The following is a description of a gene set: Changes in mouse liver mRNA profiles following intraperitoneal cytokine injection. Either interferon-gamma-/-, albumin-cre(-) Socs3(w/fl) mice, or albumin-cre(+) Socs3(-/fl) mice were injected with either phosphate-buffered saline, interferon-gamma, or interfeukin-6, and livers taken after 4h. from publication Croker BA, Krebs DL, Zhang JG, Wormald S, Willson TA, Stanley EG, Robb L, Greenhalgh CJ, Förster I, Clausen BE, Nicola NA, Metcalf D, Hilton DJ, Roberts AW, Alexander WS (PMID 12754505) studied in species Homo sapiens Human Gene Set: GSE369_SOCS3_KO_VS_WT_LIVER_UP Genes up-regulated in livers: SOCS3 knockout versus wildtype., and this is the list of marker genes: GOT1, SHQ1, SLC7A1, METAP2, WDR18, NUP85, BID, ELOVL6, RAP1GAP2, GOLM2, IRAG1, SPART, C1orf198, RAB33A, NPL, TRIP13, AATF, WDR55, MRPS5, XPOT, FDPS, HSPB2, RBM34, MTHFD2, DDX31, MALSU1, C21orf91, RPAP2, FOXRED1, TMEM248, PRELID2, SNRPA1, SLC7A6, PBDC1, AKAP1, HMBS, EIF6, DRC1, NUTF2, CS, TMED1, COMTD1, NOP2, SKIC3, FBXO31, TFB2M, ORC3, HSP90AA1 (NCBI Gene Id 89272), ITGB1 (integrin subunit beta 1), MRPS16, ST7, GSTO1, ZNF106, POLDIP2, ETF1, MRPL18, SDHB, HELLS, RSAD1, ABHD11, GRPEL1, PGM1, TRNT1, USP36, TUBB3, EEF1E1, RNPEP, MRM1, FLVCR1, RPUSD2, COPS6, TNFSF11, TSEN2, SCPEP1, PSMD6, CARS1, NDUFB6, XRCC5, SMYD2, DHX33, HAUS2, NAAA, YAE1, PNPO, FYTTD1, MRPS15, KBTBD8, TMED3, SDAD1, GUK1, RNFT1, ZDHHC23, TTLL4, PPP1R8, ELP5, DOHH, ATP23, RRP12, NARS2, TMED5, CCDC116, GFER, PSMA4, PUS3, USP14, CCDC86, ACACA, MINPP1, MRPL11, PAPOLA (NCBI Gene Id 84718), PIEZO1, DDX1, EIF3I, NXN, THOC5, PSMD14, PHB2, POLR3G, CDK5RAP3, UBXN4, EIF4A1, SUCLG1, TMEM160, COQ5, CRELD2, TIMM23, KCTD5, ABCC4, GTF2H2, EED, CORO2A, PSMG3, GNPNAT1, MAPK1IP1L, FRRS1, GTF2H5, RUVBL2, VDAC2, FAM185A, TMBIM1, ATP13A1, MRPL32, CALHM6, MRPL21, TFAP4, IDI1, RCN2, CHMP2A, NR2C2AP, C1QBP, STIP1, CLPP, ARHGDIG, LPCAT3, LSM7, NAF1, UTP18, PDK1, RPP25, TXNL4A, NOB1, NOP10, HSP90AB1, TEX264, BCAT1, CHAMP1 (NCBI Gene Id 84453), POLR1G, OSTC, MRPS14, RRS1, SRP72, CYB5B, TADA2A, PDSS2, PIGY, SNRPD1, FASTKD2, PDIA3, MRPL47, LGI2, PIGF, PWP2, RBM27, ST6GALNAC4, QTRT1, NAA50, EMC4, RSL24D1, LGR4, CCDC85B, LARP1, IFRD1, APEX1, MLLT6, RXYLT1, ERH, SRPRA, DYNLL2, G6PD